The following is a description of a gene set: Carious teeth species: Homo sapiens Human Gene Set: HP_CARIOUS_TEETH Caries is a multifactorial bacterial infection affecting the structure of the tooth. This term has been used to describe the presence of more than expected dental caries., and this is the list of marker genes: GTF2IRD1, PARN (poly(A)-specific ribonuclease), ABL1, HIRA, LAMB3, PDZD7, LIMK1, JMJD1C, SLC37A4, PTCH2, ASL, TCIRG1, TP63, PTCH1, TARS1, TERT, THOC6, RBM28, MAPRE2, USH2A, ARVCF, SFRP4, FKBP6, ATR, BUD23, ADNP, FERMT1, AKT1, GALNS, ELN, RREB1, GTF2IRD2, UFD1, OFD1, MEGF8, TERC (NCBI Gene Id 7012), DKC1, FGFR2, SEC24C, MKRN3, RUNX2, GP1BB, RNF113A (ring finger protein 113A), SUFU, TINF2, LIFR, GLB1, PWAR1, CNNM4, PWRN1, RFC2, ALPL, CREBBP, CRLF1, METTL27, MBTPS2, ERCC6, SCNM1, SNORD115-1, ERCC3, TBL2, ENPP1, KRT14, LAMC2, APC, FGF10, CAV1, SNORD116-1, BAZ1B, SLC19A1, NECTIN1, SLF2, CTNND1, SGMS2, ACP4, SBDS, SNRPN, AARS1, FGF3, MPLKIP, HERC2, NPAP1, TBX1, LAMA3, PLEC, GTF2E2, CTSK, SLC24A4, COL2A1, DNAJC30, KMT2D, CLIP2, GJA1, EFL1, ADGRV1, PKP1, RTEL1, SRCAP, ANAPC1 (anaphase promoting complex subunit 1), B3GALT6 (NCBI Gene Id 126792), COL3A1, EP300, DNAJC21, TBCE, STX1A, IFIH1, TGFB1, RECQL4, PPP1CB, USB1, HLA-DRB1, MAGEL2, COL7A1, WRAP53, ERCC8, NCF1, FAM111A, MMP13, AGA, GTF2H5, NPM1, ATP6V1A, CTC1, KDM5A, TYMS, PERP, CDH1 (NCBI Gene Id 999), TNFSF11, ATP6V0A2, NOP10, VDR, COMT (catechol-O-methyltransferase), COG6, SHOC2, CLCN7, NHP2, MMP1, DPH5, AP3B1, CDH3 (NCBI Gene Id 1001), COX4I2, CCR6, SNRPB, PGM2L1 (phosphoglucomutase 2 like 1), FGFR3, OCRL (NCBI Gene Id 4952), TRPV3, SATB1, SOX9, ERCC2, VPS37D, TMEM270, ATP6V1E1 (ATPase H+ transporting V1 subunit E1), UBE3B, MYO7A (myosin VIIA), ARSB, KLK4, ZMYM2, COL17A1, TRPS1, SEC23A, CDH11, CCN2, IRF5, EIF4H, WHRN, PAX1, IFT52, CARS1, GTF2I, SLC10A7, PEPD